The following is a description of a gene set: Human Gene Set: WP_SELENIUM_METABOLISM_AND_SELENOPROTEINS studied in species Homo sapiens Selenium metabolism and selenoproteins, and this is the list of marker genes: SELENOM, DIO2, CTH, SCLY (selenocysteine lyase), SELENOT, TXNRD2, SELENOP (selenoprotein P), SP1, GPX1, NFE2L2, SARS1, SELENOI, SEPSECS, RELA, PSTK, SELENOS, MSRB1, SP3 (NCBI Gene Id 6670), SELENBP1, SELENON, SELENOK, CREM, SECISBP2, GPX2, SELENOH, SELENOW, SELENOO, GPX3, GPX6, RPL30, EEFSEC, DIO1, TXNRD3, SELENOF (selenoprotein F), SELENOV, FOS, TXNRD1, JUN, SARS2, SEPHS2, GPX4, SEPHS1, POU2F1, TRNAU1AP, FABP1, DIO3, NFKB1